The following is a description of a gene set: from publication Yevshin I, Sharipov R, Kolmykov S, Kondrakhin Y, Kolpakov F (PMID 30445619) studied in species Homo sapiens Genes containing one or more binding sites for (ZNF322) in their promoter regions (TSS -1000,+100 bp) as identified by GTRD version 20.06 ChIP-seq harmonization. Human Gene Set: ZNF322_TARGET_GENES, and this is the list of marker genes: DR1, LRFN1, TP53RK-DT, UMAD1, ANKRD44, SCN2A, LTO1, DNAH6, VPS51, SNAP23, REX1BD, EXD2, MED17, CCDC134, PCNX1, NTN3, NBAS, ZNF43, KMT2C, F2RL1, ENSG00000272384, PDE4D, ZSWIM2, PHETA1, CALM1, PRR15, CISD1, CTPS1, DLG4, GCFC2, PLK3, KRTAP5-14P, HSD17B4, NMT1, KLHL21, MSH5-SAPCD1, EGLN2, ARID1A, LINC01276, CFL1, MBD6, ERCC6L2-AS1, CYP2T1P, SP4, CAPN10, ENSG00000261335, ETFDH, SORBS3, KIF3A, PPP6R2 (NCBI Gene Id 9701), CSK, NR5A2, UBA52, EFCAB11, SCN7A, MIER1, UBC, CREM, C8orf34-AS1, GCA, CNNM2, ADCY3, PUS10, ERLIN2, CHD5, LINC00674, USP44, PTCD1, DTNA, LDHB, NUDT19-DT, PTPN1, CSNK1E, NFYC, SREK1IP1, GAD1 (NCBI Gene Id 50977), MKNK2, ZNF540, SCNN1A, POP4, RPA3, MFN1, FZD2, PIM2, FBXW11, SYNGR4, FBXO25, OGA, KIZ, EML2, INO80D-AS1, EMP2, VTRNA1-3, GPATCH2, PPP1R9A, METTL2B, CNNM4, SH3BP5, TBC1D8B, PNKD, SYDE2, ZNF579, TCERG1, ZBTB17, FERMT2, CCND3, PPFIA3, STRADA, LTBP4, MGAT5B, PTK2B, LIAT1, TREX1, XIAP, NCKAP5, DND1P1, LINC01775, RIMOC1, USP2 (NCBI Gene Id 9099), PCGF2, LINC00963, ICMT-DT, ZSCAN29 (zinc finger and SCAN domain containing 29), NDRG2, H2BC11, FBXO24 (NCBI Gene Id 94779), TMEM50B, HSPE1-MOB4, TNIP1, WEE1, LINC03011, CRIP3, RNF168, MIR124-1HG, SEMA6A, RPL3, ZNF564, KCTD9P2, MKRN1, AK4, FOXO4 (forkhead box O4), FBXW7, DIRC3, ZNF629, TBPL1, RFX5, SNHG19, ARHGAP4, OLFM1, VPS53, ZDHHC18, GALNT16-AS1, PRORP, TRAV6, MIR6796, GXYLT2, RFFL, WBP11, NFE2L1, AFG1L, CDCA7L, PRUNE2 (prune homolog 2 with BCH domain), COX14, CNNM3, TMEM120B (transmembrane protein 120B), SLC25A11 (solute carrier family 25 member 11), SPRTN, EIF2D, MAFB, RAB34, PDXP, RPL7L1, DDX39B-AS1, SLC16A11, RBBP5, ZFP1, KHNYN, EPS15, PIP5KL1, CNTD1, METTL27, TDRKH, HERC4, PRRT4 (proline rich transmembrane protein 4), ARID1B, CENPS-CORT, MIR1915, SMIM45 (small integral membrane protein 45), CGGBP1 (CGG triplet repeat binding protein 1), SRP14-DT, NFE2L1-DT, CCDC106 (NCBI Gene Id 29903), S1PR1, TANK, WDPCP, SNORD13, GPI, EIF3K, ATN1, AKAP12, POM121C, SMIM27, SLC35E2B, TTI2, RNF7, ABCF2, OLMALINC, HHIP, SLC35E4, SUMO2P17, ARRDC3, LHCGR, RNF4, ZYG11B, DOCK5, LINC01411, GTF3C2-AS2, IL6, GRN, RPL10, MAT2B, PAMR1, SIAH2, MRPL32, ARMH1, IFNLR1, TEDC2, FAAHP1, RCAN1, KCNJ5-AS1, CEP126 (centrosomal protein 126), GPALPP1, AIFM2, FGG, YAP1, PIERCE2, GNAS-AS1, CCDC57 (coiled-coil domain containing 57), MTF2, ABCA17P, IMPDH1P4 (inosine monophosphate dehydrogenase 1 pseudogene 4), ABCA3, MZT2A, IER5, URI1, PRLR, CDH22, LIMS1, SUPT16H (SPT16 homolog, facilitates chromatin remodeling subunit), MXI1 (NCBI Gene Id 4601), ENSG00000241525, GPR161, BEX1, NMB, ZNF512, TRMU, RPL27P7, MIR615, THAP8, TMEM126B, ENSG00000233230, ARPC1B, TMEM202-AS1, GRB2, NRF1, GPR20, PML, MYC, IQCD, ITGB3BP, SETD5, TMEM101, ZMYM6, EXOC3, FBXO17, ZNF224, RBM11, PRKCB, GNAS (GNAS complex locus), CLPP, AARS2, TMEM9B-AS1, ENSG00000224865, F12 (NCBI Gene Id 58992), UACA, NDUFS6, HIRIP3, FOXM1 (NCBI Gene Id 2305), TBCK, FAM151B-DT, SGK1, MIR1915HG, CRTAP, ILF2 (NCBI Gene Id 3608), COPG2, CHCHD10, PHOSPHO1, FNBP1, SMURF2P1 (NCBI Gene Id 107133516), MIR34AHG, H2BC5, TMEM30A, DGAT2L7P, PAIP2, TNNC2, KLK4, TMEM9B, SEMA4A, NDUFB8, C12orf60, RPL23AP19, LINC02916, NAA80, SLC16A2, IFT20, RECK, HCP5, LINC02489, NDUFA12, ITGAL, MTND5P11, SRSF10, BPNT1, LLGL2, SGSM1, TSTD2, RBISP3, SPEF2, CLIC1 (chloride intracellular channel 1), FALEC, YTHDF2, SLC39A1, NUFIP2, CEP120, ALKBH1, KRTAP10-13P, GIPC1, MSH5, DDX11-AS1, PALLD, SIRT3, MIR4418 (NCBI Gene Id 100616433), GPRC5C, ZNF627, ATXN2, AKR1A1, TTC9B, ASCC2, TMEM17, NDUFS5, FAXDC2, PSMC1, HHIP-AS1, PSMA2, FOXO6, TIAL1, MIR4453HG, GMNN (geminin DNA replication inhibitor), ZDHHC1, STX1A, CD27-AS1 (CD27 antisense RNA 1), DOHH, GBF1, GALE, PHACTR3, SCPEP1, CEP170, CCDC62, KANSL1, LDLR, HIGD2A, MTCO3P12, LINC00459, RSPRY1, SHB, AAAS, KMT2E-AS1, PRKAR1A, XPO1, RASGRF1, PSMB3, UBE2D4, INAVA, TGFA, MAGED2 (NCBI Gene Id 10916), CCDC138, ZSWIM3, PDCL3, LINC02695, DCP1A, CDKL3, IFT81, GTF3C2, MGAT4B, MIR6835, BAHCC1, TMEM59, IDE, CXXC5, PIN4, MAP4K1, LIMS2, LPIN3, ITGA11, SPATA17, SNX19, ALDOC, ZMYND15 (NCBI Gene Id 84225), PMM1, LYPLA1, SYMPK, SH3D21, IMPDH1, PAPSS1, SEC22C, ARHGAP33, KLRC4-KLRK1, CDC42EP1, TAPBPL, STKLD1, MAPK14, GALK2, METTL2A, CTNND1, CAPN1-AS1, PTPRF, RAB11FIP4, MIR365A, DELE1, MRTFA, ZNF474, SON, CDK12, NOP16, VCAN, RDM1, MDGA1 (MAM domain containing glycosylphosphatidylinositol anchor 1), ELP3, GORASP1, JUN, LXN, RTL8C, DENND1A, LINC03065, ST7-OT4, RAC2, NUS1, TTC19, MPP2, PDE11A, LINC02698, RPL37, TMTC3, TRAPPC4 (trafficking protein particle complex subunit 4), SQSTM1, TMEM167B (transmembrane protein 167B), RPS25, KLRC4, MRPL49, RBMS3-AS3, ZNF438, CCDC18-AS1, VPS26C, TLE5, NELL2, MIR4638, PPP1R7, ZNF277, ENSG00000260830 (NCBI Gene Id 107984643), MAFF, ERAP1, PIGU, ST6GALNAC6, ACADVL, TSR1, SNORA71A, HOTAIR, BMPR1B, NAA38, TRAPPC6B, ATG5, LINC01232, LARP4, TRIM35, RTCB, DYRK4, ENDOG, MYCBP, SNORD83B, AP3D1, IRAK2, SPG11 (SPG11 vesicle trafficking associated, spatacsin), JUN-DT, RPAP3-DT, VIM, DIPK1A, POLD4, METTL13, ISYNA1, RALBP1, TRAPPC2B, ALDH7A1, RIT1, KIF20B, RNU6-163P, UXS1, HNRNPL, CAPN1, POLR2G, RRAGC-DT, HAND2, APLP1, STN1, ENTREP3, EMC3, DMAP1, C4orf46, SHISA8, ZNF230, SPAG4, SEPTIN7P9, KIAA1143, STXBP5L, DNAI4, OXSR1, PTPN12, C2orf72, NUFIP1, SOX2-OT, CXXC1, PROX1-AS1, GUSBP18, LINC01596, MMADHC, ZNF475, NCOR2, UQCC1, DZANK1, NEDD1, EPN2-AS1, TTC32-DT, TAX1BP1, TTC32, PERP, NCOA2, GLB1L, PBX1, TDP1, ABHD16A, HRK, ALDH1L2, ANGEL1, KCTD9, DDX11, BARHL2, ZSWIM7 (zinc finger SWIM-type containing 7), GTF2IRD1P1, MYO10, LINC01623, TAF4B, WDR38, BORCS8, EMC3-AS1, ZNF684, PEMT, MYCL, ZNF547, ITPKB-AS1, APOE, PLCXD1, THUMPD3-AS1, MVB12A, ERICH1, SLIRP, IRF2BP2, MDH1, SEMA7A, H3P25, RDM1P5, ZFP30, KDM2B, NT5C1A, AP1G2, OBSL1, MPV17L2, GFI1B, WDR62, CYP4V2, PPA2, PNP, GALNT5 (NCBI Gene Id 11227), SEMA3E, LINC01730, C2CD3 (C2 domain containing 3 centriole elongation regulator), FBXO11, RFX5-AS1, DDX39B, SLC6A6, PSMB5, ZNF182, ITPR1, RAB37, TRIM65, CAPG (NCBI Gene Id 822), PPM1B, SLC46A1 (NCBI Gene Id 113235), RBMS3, VPS33B-DT, PRCD, DRG2, CHD7, DTX3, RNF182, COASY (NCBI Gene Id 80347), CENPS, PNKP, BRWD3, CDK8P1 (NCBI Gene Id 359940), WDR73, PDE1A, PDE4B, CDC42EP3, LINC00265, CBLN3, PLD3, ZNF230-DT, SNX27, PACSIN3, WDR26, TLX1, ADGRE2, ZDHHC16, CLCN3, NELFE, CASTOR3P, DESI2, FAM230G, MRPL36, ZNF56P, PDXP-DT, POM121, ARID5B, TRIM41, AAMP, MAP3K4, SEC11A, MIR99AHG, PRPSAP1, HSPD1, RNF11, RARA, CHRM3, TRAIP, ZGPAT, GRM4, PLEKHA3, TRAK2, TKTL1, HAP1, SPIN2B, DNASE2, TRPT1, SEPTIN11, PRORSD1P, WDR75, FAM114A2, EPN1, PCTP, VPS33B, RTN4, SMPD4BP, AIMP1, POLR3F, TES, HK1, PRRX2-AS1, MYL12A, ALDH1A3, POLR1B, OS9, SNORD60 (NCBI Gene Id 26788), MUS81, FAF1, PNRC2, ECH1, SRD5A3-AS1, MAN2A2, EPRS1, SPACA6, MISP3 (MISP family member 3), SVOP, EXOC8, PGAM1P5, ACSM2A, IMPA2, LINC02926, TMSB15A, TMEM167B-DT, GSE1, VMP1, TMEM18, RNU7-174P, ZNF227, HLA-DMA, NEUROD2, KMT2B, TP53TG1, SERINC5, PPIA, HRAS, APC, PFDN6, IL11RA, KMT2E, CYP2G1P, CDKN2C, ZNF217, SMTN, DNAJC27-AS1, USP38, PIGL, CEP290, SPACA5, UGCG, CCDC112, UBE2Z, JUP, ASH1L, CDKN2A, HMGCR, SAMD10, PASK, TCEA1, LINC01562, TOMM70, CCNO-DT, SKAP2, GOLPH3L, LSM10, PODXL (NCBI Gene Id 5420), RFXANK, RPSAP75, MBL1P, CYRIB, EIF4A3, TCF15, SKIC2, SPTB, LINC00663, LINC01703, CPSF4, DLG2, TMEM87B, LINC01881, ENSG00000265055, STX1B, RN7SL352P, MBTD1, SETD6, STMP1 (NCBI Gene Id 649778), BRD2, BRF2, BLTP2, GPR160P1, ZHX2, NOL12, ZNF790, PEX13, FAM110A, HSD17B1-AS1, CHD8, ZNF362, MRPS23, PALS1, MIR4744, MAP2K6, LOX, TSC22D1, PPP2R3C, ATP10D, GBA1, CDCA2, STAT3, PYGB, MRPL55, MAST4, H4C11, NAA60, SOS2, COMMD3, HYAL3, TEDC1, PLS3, TMEM53, RNU5F-1, FNBP1P1, LRCH4, RPP25L, OACYLP, NPHS1, DAND5 (NCBI Gene Id 199699), TNFAIP1, SDHB, ISG20, HINFP, SPATS2L, PACSIN2, SNX21, REXO4, PRKRIP1, HOXA-AS2, CBLL1, RPIA, CACNA2D4, GGH, DST, SLC22A5, ENSG00000236543, TMEM107, TMEM87A, PSMG1, CNOT4, MIR6880, FAU, IGSF21, ICMT, COLGALT1 (NCBI Gene Id 79709), RNF113A, PRSS23, CASTOR1, URGCP, DDX56, ECSIT, RNF167, SIPA1L3, RAB5C, THOP1, HOMER2, HDAC2-AS2, EPOR, HDLBP, UTP18, ZNF131, CCDC39-AS1, DEPP1, PAFAH1B3, CCPG1, APBB3, MRO, PUM1, MDN1, GFOD1-AS1, PLEKHA7, PMS2P3, SLC5A4-AS1, SF3B1, GANC, TSSC4, H2AC11, CA14, TMEFF1 (NCBI Gene Id 8577), HSPE1, SLC35A4, HCFC1-AS1, CGN, PDE7B, CREB5, CCNO, DUSP7, ZNF764, ANXA11, TM9SF3, ARIH1 (ariadne RBR E3 ubiquitin protein ligase 1), CYB5D1, SH2D6, ERI3, PARVG, DCAKD, CROT, S1PR1-DT, FAM13B, TMEM39A, CLSPN, ATP6V0B, TUBGCP4, MAP3K10, DNAI3, NGDN, WDR46, FBXL19, MYBL1, VASN, SERTAD2, CDK4, EFL1P1, ADRM1, PEX5, DST-AS1, MAP2K4 (NCBI Gene Id 6416), ZNF250, ANKLE2, TP53RK, ATP6V1G1, CDK19, SH3KBP1, DUSP5-DT, GPX1, PSMD13, SGSM2, LINC02870, PARP8, TNKS, DYTN, CTDSPL2, NCBP1, ACOT8, ZNF106, ARFRP1, SMAD7, TMEM30A-DT, TMEM52, MEG3, IGFLR1, NLRP1, LINC03100, FHAD1, GCNT2, PITPNC1, ZNF654, C19orf12, SLC38A4, CCDC124, ELF3, HAND2-AS1, RGS16, APLP2, ZBTB4, ANGPT2, FABP5P3, STOML1, PPP1R14B, FHL2, ERCC6L2, FSTL5, APOBEC3B, BORCS8-MEF2B, CPSF1, PKM